The following is a description of a gene set: studied in species Mus musculus from publication Martin D, Galisteo R, Ji Y, Montaner S, Gutkind JS (PMID 17934524) Kaposi's sarcoma (KS) is the most frequent AIDS-associated malignancy, etiologically linked to the infection with the human herpesvirus 8 (HHV-8/KSHV). This member of the gamma-herpesviridae family encodes 81 open reading frames, several bearing oncogenic potential. A constitutively active virally encoded G protein-coupled receptor (vGPCR) readily induces KS-like lesions when expressed in endothelial cells in vivo, and unmasks the oncogenic potential of other HHV-genes in a paracrine fashion. How vGPCR causes endothelial cell transformation is still not fully understood. Using full-genome microarray analysis we show here that the expression of nuclear factor-kappaB (NF-kappaB)-regulated genes is a prominent feature triggered by vGPCR in cells expressing this viral oncogene and in cells exposed to vGPCR-induced secretions, thus mimicking its paracrine effect. Indeed, vGPCR activates the NF-kappaB pathway potently, and NF-kappaB activation is a hallmark of both human and experimental KS. Of interest, whereas constitutive NF-kappaB signaling is not sufficient to promote endothelial cells transformation, NF-kappaB function is strictly required for vGPCR-induced direct and paracrine neoplasia. Taken together, these results strongly support the role of NF-kappaB regulated genes in KS pathogenesis, thus providing the rationale for the development of novel mechanism-based therapies for this angioproliferative disease. Down-regulated genes in the expression signature of direct and paracrine viral GPCR signaling in endothelial cells. Human Gene Set: MARTIN_VIRAL_GPCR_SIGNALING_DN, and this is the list of marker genes: STBD1, PGF, OR13C7, LMBR1L, SMPD3, CFH, EXTL1, EFNB3, HLA-B, MAN2A1, OR5B12, UBN1, BRD1, ESX1, NOD1, TCOF1, TRAK1, SLCO1A2, UNCX, HTT, WT1, TF, MRPS22, MEAK7, H1-1, TCERG1, TBC1D1, SMS, PSPH (phosphoserine phosphatase), NEBL, RNF122, PANX2, PPT2, BRSK1, TAF13, LSM6, BIK (NCBI Gene Id 638), OR5AR1, FOSL1, ARIH2, ZNF622, CD86, BFSP2, PLA2G2F, ZNF7, SRP9, HTR1B, ALDH18A1, DGKQ, FRMD4B, VCAN, LGR6